Given this list of marker genes NEDD9, AURKA, HDAC6, KIF19, MAP4, RRP7A, here is a description of the gene set: Human Gene Set: GOBP_CILIUM_DISASSEMBLY studied in species Homo sapiens A cellular process that results in the breakdown of a cilium.